Given this list of marker genes CYP2C8, CYP2D6, UGT2B15, CYP2C9, UGT1A10, SULT2A1, UGT1A8, CYP2A6, FMO1, CYP3A4, SULT1A1, CYP2E1, CYP1A1, UGT1A4, CYP1A2, SULT1E1, UGT2B7, CYP1B1, CYP3A5, FMO3, CYP2C19, here is a description of the gene set: Tamoxifen metabolism studied in species Homo sapiens Human Gene Set: WP_TAMOXIFEN_METABOLISM